Given this list of marker genes PTPN1, ACAA2, TSPAN4, LBP, IL1R1, GPX3, GRAMD2B, MPO, SOCS3, CEBPB, TAPBP, ALDOC, MAN1A1, NMI, PSMB8, UPP1 (NCBI Gene Id 7378), FBP1, ANXA8L1, IRF1, ELF3, TNFRSF1A, SCT, TMEM176A, LCN2, STAT3, ST3GAL1, CYB561, RGS4, BCL3, LRG1, SQOR, RASA3, FGG, VWF, TMEM176B, CXCL14, XBP1, KLF10, HAS1, GPCPD1, RHOU, KNG1, RNASE2, here is a description of the gene set: studied in species Mus musculus Leukemia inhibitory factor (LIF) mediates the hypothalamo-pituitary-adrenal stress response. Transgenic mice overexpressing LIF in the developing pituitary have altered pituitary differentiation with expansion of corticotropes, maintenance of Rathke's cleft cysts, and suppression of all other pituitary cell types. Affymetrix GeneChips were used to identify modulators of LIF effects in corticotrope (AtT-20) and somatolactotrope (GH(3)) cells. In addition to genes known to respond to LIF in corticotrope cells, corticotrope-specific changes were also observed for genes involved in glycolysis and gluconeogenesis, transcription factors, signaling molecules, and expressed sequence tags. Two transcription factors identified, CCAAT/enhancer-binding protein beta (C/EBPbeta) and glial cell-derived neurotrophic factor (GDNF)-inducible factor (GIF), dose-dependently induced expression of the rat POMC promoter when overexpressed in AtT-20 cells. LIF further induced POMC transcription with C/EBPbeta, but not with GIF. C/EBPbeta also induced expression of the SOCS-3 promoter that was further enhanced by cotreatment with LIF. However, GIF did not affect SOCS-3 expression. These results indicate that C/EBPbeta and GIF are downstream effectors of LIF corticotrope action. LIF also stimulates the expression of inhibitors of its actions, such as SOCS-3 and SH2 domain-containing tyrosine phosphatase-1. alpha(2)-HS-glycoprotein (AHSG)/fetuin, a secreted protein that antagonizes bone TGFbeta/bone morphogenic protein signaling, was induced by LIF in a signal transducer and activator of transcription-3-dependent fashion. Pretreatment with AHSG/fetuin blocked LIF-induced expression of the POMC promoter independently of SOCS-3. Thus, using GeneChips, C/EBPbeta and GIF have been identified as novel mediators and AHSG/fetuin as an inhibitor of LIF action in corticotropes. Human Gene Set: ABBUD_LIF_SIGNALING_1_UP from publication Abbud RA, Kelleher R, Melmed S (PMID 14576184) Genes up-regulated in AtT20 cells (pituitary cancer) after treatment with LIF.